The following is a description of a gene set: tRNA processing species: Homo sapiens Human Gene Set: REACTOME_TRNA_PROCESSING, and this is the list of marker genes: TRDMT1, ADAT1, RPP21, POP5, RPP30, RPPH1, NUP42, AAAS, NDC1, NUP37, ADAT2, POM121C, CPSF1, RTRAF, SEH1L, THG1L, RPP25, XPOT, HSD17B10, TRMU, NSUN2, RAN, PUS7, NUP88, CDKAL1, NUP155, TRIT1 (NCBI Gene Id 54802), GON7, METTL1, NUP85, TPR, CLP1, TRMT5, NUP62, TSEN34, NUP50, NUP205, TRMT11, RPP40, TRMT44, NUP35, WDR4, RPP14, TRMT12, TSEN54, POP1, TRMT13, NSUN6, FTSJ1, NUP98, LAGE3, URM1, MT-RNR1, NUP160, PUS1, TRMT9B, QTRT2, NUP58, MTO1, TP53RK (TP53 regulating kinase), NUP107, CTU1, TRMT61B, C2orf49, ELAC2, TRMT10A, TRNT1, TSEN2, TYW3, TRMT1, NUP93, NUP43, NUP188, CSTF2 (cleavage stimulation factor subunit 2), DDX1, RTCB, NUP133, TRMT112, POP4 (POP4 homolog, ribonuclease P/MRP subunit), NUP54, ZBTB8OS, NUP153, PUS3, CTU2, RAE1 (ribonucleic acid export 1), PRORP (NCBI Gene Id 9692), ADAT3, DUS2, CPSF4, TYW5 (tRNA-yW synthesizing protein 5), ALKBH8, LCMT2, MT-RNR2, GTPBP3, TYW1, QTRT1, NUP210, TSEN15, TRMT61A, TRMT6, THADA, TPRKB, FAM98B, NUP214, RANBP2, POM121, OSGEP, EPRS1, POP7, RPP38, TRMT10C, SEC13